Given this list of marker genes HDAC1, TFDP1, MAX, CCNE1, LIN37, TOP2A, RBL2, E2F4, LIN54, RBL1, CCNE2, CDC25A, LIN52, RBBP4, CCNA2 (NCBI Gene Id 890), CDK2, MYBL2, DYRK1A, CDC6, CDK1, E2F5, LIN9, CCNA1, E2F1, PCNA, TFDP2, MYC, here is a description of the gene set: G0 and Early G1 species: Homo sapiens Human Gene Set: REACTOME_G0_AND_EARLY_G1